Given this list of marker genes Sos1, Notch1, Hes1, Sox4, Sos2, Flt3, Fnip1, Nudt21, Flcn, Xrcc4, Lig4, Prkdc, Hes5, here is a description of the gene set: The process in which a precursor cell type acquires the specialized features of a pro-B cell. Pro-B cells are the earliest stage of the B cell lineage and undergo heavy chain D and J gene rearrangements, although they are not fully committed. Mouse Gene Set: GOBP_PRO_B_CELL_DIFFERENTIATION studied in species Mus musculus